The following is a description of a gene set: species: Homo sapiens Several DNA repair genes contain p53 response elements and their transcription is positively regulated by TP53 (p53). TP53-mediated regulation probably ensures increased protein level of DNA repair genes under genotoxic stress.<p>TP53 directly stimulates transcription of several genes involved in DNA mismatch repair, including MSH2, PMS2 and MLH1. TP53 also directly stimulates transcription of DDB2, involved in nucleotide excision repair, and FANCC, involved in the Fanconi anemia pathway that repairs DNA interstrand crosslinks. Other p53 targets that can influence DNA repair functions are RRM2B, XPC, GADD45A, CDKN1A and PCNA. Interestingly, the responsiveness of some of these DNA repair genes to p53 activation has been shown in human cells but not for orthologous mouse genes. Contrary to the positive modulation of nucleotide excision repair (NER) and mismatch repair (MMR), p53 can negatively modulate base excision repair (BER), by down-regulating the endonuclease APEX1 (APE1), acting in concert with SP1.<p>Expression of several DNA repair genes is under indirect TP53 control, through TP53-mediated stimulation of cyclin K (CCNK) expression. CCNK is the activating cyclin for CDK12 and CDK13. The complex of CCNK and CDK12 binds and phosphorylates the C-terminal domain of the RNA polymerase II subunit POLR2A, which is necessary for efficient transcription of long DNA repair genes, including BRCA1, ATR, FANCD2, FANCI, ATM, MDC1, CHEK1 and RAD51D. Genes whose transcription is regulated by the complex of CCNK and CDK12 are mainly involved in the repair of DNA double strand breaks and/or the Fanconi anemia pathway. Reactome Pathway: TP53 Regulates Transcription of DNA Repair Genes part of: Transcriptional Regulation by TP53, and this is the list of marker genes: SSRP1, TCEA1, CDK12, ELOA (elongin A), POLR2K, GTF2H4 (general transcription factor IIH subunit 4), POLR2L, NELFE, NELFB, CCNK, ATF2, POLR2E, FANCD2, POLR2H, GTF2F2, GTF2H5, ELOA2, ELOB, ELOC, FANCC, POLR2D, DDB2, NELFCD (NCBI Gene Id 51497), GTF2H2, GTF2H3, ERCC2, CCNT1, CTDP1, GTF2F1, CDK7, ATM, MNAT1, PMS2, MSH2, CCNT2, JUN, ERCC3, FANCI, CDK9, POLR2B, ATR, POLR2I, POLR2G, CDK13, POLR2F, POLR2J, MLH1, POLR2A, MDC1, FOS, SUPT16H, BRCA1, CCNH, NELFA, TP53, GTF2H1, SUPT4H1, SUPT5H, ELL, POLR2C (NCBI Gene Id 5432), CHEK1 (checkpoint kinase 1), RAD51D